Given this list of marker genes Metap2, Rnpepl1, Metap1d, Metap1, Actmap, here is a description of the gene set: species: Mus musculus Catalysis of the release of N-terminal initiator methionine from peptides. Mouse Gene Set: GOMF_INITIATOR_METHIONYL_AMINOPEPTIDASE_ACTIVITY